Given this list of marker genes CRHR2, ADGRE2, ADGRL4, SCTR, ADGRG2, GIPR, PTH2R, CRHR1, GLP1R, CALCRL, VIPR1, LINC02210-CRHR1, PTH1R, VIPR2, ADGRL1, GCGR, GLP2R, ADGRL2, ADGRE1, CALCR, GHRHR, ADGRE5, ADGRL3, ADCYAP1R1, here is a description of the gene set: Human Gene Set: WP_GPCRS_CLASS_B_SECRETINLIKE GPCRs, class B secretin-like species: Homo sapiens